Given this list of marker genes Gltpd2, Gltp, Mttp, Cptp, Plekha8, here is a description of the gene set: Removes a ceramide 1-phosphate from a membrane or a monolayer lipid particle, transports it through the aqueous phase while protected in a hydrophobic pocket, and brings it to an acceptor membrane or lipid particle. studied in species Mus musculus Mouse Gene Set: GOMF_CERAMIDE_1_PHOSPHATE_TRANSFER_ACTIVITY